Given this list of marker genes Sirt6, Dclk1, Taf8, Cd9, Kdm6a, Slc9a1, Crabp2, Slit1, Stat5b, Agt, Pabir1, Eif4g1, Fgf13, Jade3, Usp9x, Ptch2, Colq, Bcl2, Pi16, Grn, Stk11, Tsg101, Nr3c1, Sesn2, Adam10, Cdh1, Rgs4, Pin1, Prr5, Cgrrf1, Mdk, Ctr9, Dyrk1a, Smarca4 (SWI/SNF related, matrix associated, actin dependent regulator of chromatin, subfamily a, member 4), Disc1, Foxc1, Gsk3b, Chrnd, Rpl4, Twf2, Bcl6, Ednra, Ceacam1, Nanos1, Ttn, Tbx1, Lhx1, Adm, Dmbt1, Haglr, Col9a1, Cd2ap, Gata6, Cib1, Slc23a2, Dab2, Dact3, Raph1, Gpr149, Adnp, Suv39h1, Sfn, Armc12, Osgin1, Adra1b, Slc39a12, Map2k4, Grhl2, Ncor1, Cpne6, Rftn1, Evc, Esr1, Prkg1, Il6ra, Rgma, Ppard, Jade1, Clstn3 (calsyntenin 3), Fbp1, Ccn4, Plau, Hlx, Rab21, Gdf9, Pml, Cyfip1, Musk, Minar1, Pou3f2, Ghrh, Caprin2, Map7, Comt, Edn2, Gins1, Megf8, Smad7, Ahi1, Taf10, Pls1, Ybx3, Rtn4, Adrb1, Nrp1, Bbc3, Slc1a2, Cdk5, Trpv2, Map2, Wnt3a, Rxra, P2rx5, Sertad1, Apod, Mcemp1, Areg, Sav1, Nedd4l, Commd5, Pde4d, Tnr, Mir467a-10, Tgfbr3, Ngf, Fubp1, Scnn1b, Fgf7, Plxna1, Sbds, Wnt11, Sema7a, Rarb, Nr5a2, Hoxa11, Fes, Afg3l2 (AFG3-like AAA ATPase 2), Wrn, Chd7, Ppp1r13l, Atp8a2, Bcl2l11, Tmem196, Mir467a-9, Tshr, Cga, Sod1, Atf5, Fam107a, Ist1, Dysf, Rtn4r, Inhba, Sdcbp, Actn3 (NCBI Gene Id 11474), Prkn, Cryab, Zfp568, Selenon, Slc25a33, Alox8, Auts2, Sema6c, Plekha1, Crhr2, Sgpl1, Golga4, Helt, Foxo3, Smpd3, Pik3ca, Lncpint, Lep, Cxcr4, Dhcr7, Serpine1, Gdf2, Impact, Col14a1 (NCBI Gene Id 70486), Mir1a-2, Bmpr1a, Sema3a, Mymx, Taf9b, Spg11, Cdkn1a, Slitrk6, Plac8 (placenta-specific 8), Hsd3b7, Flrt3, Hspa1b, Clasp2, Fmn1, Igfbp7, Sphk1, Gdf5, Wt1, Atn1, Igfbp3, Hnrnpk, Mkks, Bap1, Nppa, Gli1, Zfp830, Akp3, Odad3, Lats2, Lgr6, Guca2b, Alms1, Adipor1, Lgmn, Tex19.1, Ercc5, Dnph1, Mapk11, Hbegf, Slc4a10, Ccm2l, Nlgn3, Dab2ip, Ndufs3, Smad1, Ncoa3, Csnk2a1, Gins3, Stk3, Kdm2a, Sall1, Tmem182, Ptch1, Hrg, Bcan, Ninj1, Ier3ip1, Sema5b, Capn3, Nkd1, Wdr36, Palb2, Nfkbiz, Mul1, Ccdc85b, Sfrp2, Tbx20, Rbp4, Arid2, Dnm2, Drd2, Mir133a-2, Ip6k2 (inositol hexaphosphate kinase 2), Tle5, Ski, Ndufa13, Ehmt2, Gnas, Smo, Heg1, Pnpt1, Notch2, Rpl29, H2-Q2, Rufy3, Sphk2, Socs6, Dcbld2, Sco1, Zfp640, Psap, Lhx2, Apoa5, Pdgfrb, Cgref1, Fhl1, Rmi1, Dnaaf3, Eif2b2, Pelo, Spag9, Mtor, Zfpm2, Rnf157, H3f3a, Pak1, Foxk1, Myl2, Ppp1r9b, Hey2, C9orf72, Prlr, Cdc42, Creb3, Nat8f3, Spry1, Mir34b, Dio3, Ncam1, Thbs3, Sptbn4, Dnajb2, Ptk2b, Mir467a-8, Cldn18, Ghrl, Lamb2, Wnt2, Mir467a-7, Kcnk2, Cdhr2, Garem2, Trp53, Sema4d, Stat3, Nme6, G6pdx, Mir155, Aspm, Sema5a, Ccm2, Acacb, Nin, Gnasas1, Psmd10, Zfp36l1, Gnat2, Brat1, Tiam1, Fosl2, Fgf2, Abcc1, N6amt1, Pparg, Nell2, D1Pas1 (DNA segment, Chr 1, Pasteur Institute 1), Mst1, St7l, Bmp10, Mir21a, Apba1, Rdh10, Sirt1, Fkbp8, Nubp1, Wfs1, Plxna3, Hamp2, Tspyl2, Eif4g2, Iqgap1, Sp2, Ptger4, Cops2, Otoa, Slit3, Gpr21, Olfm1, Dag1, Frzb, Plaat1, Gli3, Cdkn2c, Ly6e, Pdlim5, Myf6, Galnt3, Sfrp1, Stk4, Duox2, Acvr1c, Avpr1a (arginine vasopressin receptor 1A), Smad3, Gdf15, Ccar2, Mlst8, Pdgfra, Egfr, Hspa1a, Pou1f1, Extl3, Filip1l, Sertad2, Msx1, Ptprj, Gdi1, Reg1, Gnat1, Bst2, Csf1r, Nf2, Kif26b, Ccl11, Fto, Fshr, Wdr11, Ints1, Slc12a2, Mag, Eif4h, Tmprss11d, Por, Myoz1, Ncapg2, Hoxa5, Rptor, Prickle1, Bdkrb1, Stc2, Ntrk3, Enpp1, Flvcr1, Mme, Meaf6, Gigyf2, Pax7, Cobl, Fgf9, Tnfrsf12a, Ercc2 (NCBI Gene Id 13871), Dspp, Kmt2d, Ilk, Prdm4, Ulk1, Ddx39b, Kmt2c, Plxna4, Mt1, Trim32, Itga4, Sec61a1, Kat2a, Parp1, Gas1 (NCBI Gene Id 14451), Dicer1, Cited2, Macf1, Acvrl1, Cpq, Sesn1, Plg, Cd44, Kpna1, Wnt7b, B4galnt2, En1 (engrailed 1), Map1b, Ppara, Large1, Sohlh2, Col3a1, Klf5, Hmga2, Lin7a, Wnt7a, Tchp, Adam15, Rspo2, Tead1, Fgf8, Selenom, Gmnc, Yap1, Sik3, Rims1, Rbm10, Pmp22, Aaas, Efna5, Ankrd11, Mycbp2, Hnf4a, Gjd4, Spag6l, Tnks2, Chaserr, Smad2, Ppp2r3a, Ttl, Ep300, Shtn1, Sox9, Gap43, Cdk1 (NCBI Gene Id 12534), Brd4, Apc, Hesx1, Gsk3a, Atrx, Mir467a-6, Npm1, Cacng7, Slc6a3, Dnajc2, Ang2, Dipk2a, Gm34220, Ndufs6, Plac1, Hdac2, Bmp4, Sbf1, Adcy10, Tal2, Ccn3, Acvr1b, Prkcz, Fn1, Plag1, Hnf1b, Anxa1, Bmpr2 (bone morphogenetic protein receptor type 2), Tmed2, Bcl11a, Cd38, Ssna1, Dip2b, Ing5, Cav3, Eno1b, Tfcp2l1, Foxp1, H3f3b, Pou4f3, Tns2, Alcam, Rasal1, P3h1, Cep43, Mesp1, Mir467a-4, Alkbh1, Ptpn11, Sall4, Gata3 (NCBI Gene Id 14462), Rnf6, Arx, Sema3f, Fbxw10, Sertad3, Prlh, Lin7b (lin-7 homolog B, crumbs cell polarity complex component), Gpat4, Sema4f, Tnc, Mir449a, Ndel1, Shbg, Mymk, Mustn1, Slc6a4, Tsc22d4, Ereg, Tcf7l2, Ptn, Mapt, Fkrp, Lzts2, Agr2, Draxin, Rara (retinoic acid receptor, alpha), Pim1, Zmat3, Ninj2, Mtm1, Tomm70a, Ntn1, Bcl9, Spag6, Jade2, Synb, Phip, Cyba, Phlda2, Cxcl12, Syt4, Adrb2, Cntf, Srf, Six4, Krtap21-1, Sema6d, Fbln5, Med1, Syt1 (synaptotagmin I), Vangl2, Cela1, Lmx1b, Matn1, Rbbp7, Zp3, Gas2, Ei24, Igfbp5 (NCBI Gene Id 98676), Nek1, Mstn, Ift80, H3f5, Hsf1, Cdkn2a (cyclin dependent kinase inhibitor 2A), Sox17, Ascl3, Robo1, Hamp, Igfbp4, Prkar1a, Hdgfl2 (NCBI Gene Id 15193), Nppc, Rxrb, Trim28, Zfyve27, Mapk14, Chrna1, Wfdc1, Dlk1, Sgk1 (serum/glucocorticoid regulated kinase 1), Ddr2, Prmt2, Ercc6 (excision repair cross-complementing rodent repair deficiency, complementation group 6), Syt2, Ezh2, G6pd2, Snhg15, Amh, Pten, Csf2rb, Cryaa, Src, Sgca, Ulk2, Lin7c, Foxc2, Map3k13, Ptk7 (NCBI Gene Id 71461), Ino80, Omg, Hoxd13, C3, Plec, Dlg1, Creb1, Opa3 (optic atrophy 3), Pantr2, Cdkn1b, Stra6, Hmga1, Cth (NCBI Gene Id 99582), Prkdc (protein kinase, DNA activated, catalytic polypeptide), Crk, Unc13a, St8sia2, Trpc5, Epm2a, Thbs1, Naif1, Itgb1, Mecp2, Mir205hg, Atf2 (activating transcription factor 2), Ube3a, Igsf10, Lrp4, Safb, Rnd2, Fgf20, Arih2, Mir133a-1, Smad4, Fxn, Scaper, Agrn, Spry2, Exosc2, H19, Edn1, Cxadr, Nrn1l, Slc12a5, Mael, Sox15, Chek1, Acvr2b, Npy1r, Foxp2, Parp2, Ros1, Mir489, Mmp13, Cdc73, D7Ertd443e, Tbx2, Jarid2, Chst11, Rictor, Dcun1d3, Tgfb2, Ahr, Tro, Llgl2, Avp (NCBI Gene Id 11998), Flt4, Cadm1, Meis1, Brinp3, Gli2, Prox1, Atp1a3, Stc1, Ccr5, Sema3g, Atg16l1, Nfix, 9630013A20Rik, Bnipl (BCL2/adenovirus E1B 19kD interacting protein like), Zpr1, Zfx, Ostn, Atad3a, Ccnb2, Dscam (NCBI Gene Id 78761), Dbn1, Tnn, Gata4, Ceacam2, Eaf2, Ttc8, Pttg1, Socs2, Mir467a-2, Pin1rt1, Kdr, Anapc2, Tenm4, Ppm1f, Sos1, Ddx49, Adra1a, Sox10, Vps13a, Mbd5, Ptgfrn, Spart, Zeb2, Ccnb1, Med12, Arhgap32 (NCBI Gene Id 70677), Gins4, Islr2, Mef2c, Yy1, Afdn, Trp73, Sox2, Cpne9, Ing4, Lmx1a, Ifrd1, Tkt, Xpa, Syt17, Ext1, Brca2, Wnt3, Exosc4, Kif14, Setdb1, Il7, Ghr, Supv3l1, Sash3, Uts2r, Serpine2 (serine (or cysteine) peptidase inhibitor, clade E, member 2, NCBI Gene Id 20720), Fzd7, Nppb, Zmpste24, Fgfr3, Pygo2, G6pc1, Mt2, Htra2, Emx1, Epha7, Cacna2d2, Col27a1, Pkdcc, Hyal1, Kdm1a (lysine (K)-specific demethylase 1A), Abl2, Vil1, Ptprs, Ppt1, Llph, Mfsd8, Myh10 (NCBI Gene Id 77579), Six1, Cpne1, Cdkn2aip, Uri1, Trim46, Rad51b, Tarbp2, Tgfbr2, Tll2, Fzd9, Mex3c, Sorbs2, Map2k5, Ttc3, Zfp639, D130043K22Rik, Unc79, Rag2, Ptk2, Plaa, Trim40, Gamt, Rbbp6 (NCBI Gene Id 97359), Xbp1, Derl2, Wasf1 (WASP family, member 1), Mtpn, Cst5, App, Tnk1, Cd81, Icmt, Eno1 (NCBI Gene Id 269605), Stat5a, Apba2, Mapk1, Brca1, Ccnd2, Cyp19a1, Siah1a, Azgp1, Bmpr1b, Limk1, S1pr1, Smurf1, Flrt1, Ercc1, Nkx6-1, Ctc1, Dusp10, Nbn, Slitrk1, Hoxd11, Slc9a6, Gh, Mt3, Phb1, Vps13b, Clic4, S100b, Adrb3 (NCBI Gene Id 11556), Nog, Pkm, Myh6, Actr3, Cacna1c, Wwc2, Ddr1, Prdm11, Cfl1, Mmp14, Eppk1, Igfbp1, Tgfb1, Ptk6, Lamtor2, Gpx4, Garem1, Usp47, Cyfip2, Nrp2, Mapkap1, Slc25a25, Pex5, Hdac3, Gng4, Notch1, Ctdp1 (CTD phosphatase subunit 1), Add1, Wnt5a, Drd3, Dll1, Shh, Trip10, Lamtor1 (NCBI Gene Id 66508), Hopx, Mir449b, Rln1, Epb41l5, Slc44a4, Atrn, Pou4f2, 2810429I04Rik, Dusp6 (NCBI Gene Id 67603), Psapl1, Mcub, Rhoa, Lrp1, Smarca2, Rc3h2, Bbs4, Hyal2, Tnfaip6, Tmtc3, Igf1, Tmprss4, Ankrd26, Cdkl3, Bltp1, Rerg, Npr2, Col6a1, Lrp6, Poc1a, Ncbp1, Wnt10b, Dmd (NCBI Gene Id 93863), Cirbp, Gpd2, Rarg, Il9, Apoe, Il9r, Plcb1, Kat7, Vcl, Cer1, Armc10, Fgf1, Dvl1, Rims2 (NCBI Gene Id 72660), Septin7, Spg21, Tmem108, Slco1a6, Carm1, Cpne5, Dcaf1, Ptx3, Lpar3, Xirp1, Vps54, Selenop, Camk2d, Ghrhr, Pum2, Mad2l2, Gpc3, Ihh, Dcun1d5, Pafah1b1, Dmbx1, Bbs2, Kcnj8, Brinp2, Cxcl16, Cttn, Fgfr1, Tbx5, Six3, Ikzf1, Igfbpl1, Rtf1, Zmiz1, Dcx, Meg3, Edn3, Bin3, Akt1, Tmem38b, Nkx2-5, Mir124a-2, Psrc1, Il3, Mir449c, Hdac6, Grem1, Flt3, Mir675, Eif2ak4, Hif1a, Fgfr2, Osgin2, Krt17, Hhex, Sgip1, Prkcb, Insr, Rbpj, Sh3pxd2b, Tfap2c, Pot1b, Stil, Daxx, Foxs1 (forkhead box S1), Esrrb, Ubtfl1, Wwc1, Dbnl, Ecm1, Spr, Dcaf13, Igf2, Rai1, Ar, Msx2, Acsl4, Kazald1, Cox10, Igf1r, Adarb1, Lepr, Mndal (NCBI Gene Id 192690), Cntnap2, Slc25a4, Ppib, Adprhl1, Erbb2, Tbl1xr1, Pcdh15, Zfp950, Nrk, Nipbl, Ppan, Fendrr, Serp1, Zfp418, Spaar, Sptbn2, Sin3a, Fgf10, Mir208a, Csf1, Akap6, Rasal2, Ctnnb1, Arid5b, Cdh4, Mir467a-3, Tgfbr1, Lats1, Sh3glb1, Abl1, Sh3bp4 (SH3-domain binding protein 4), Fstl4, Rps6kb1, Mfsd2a, Wdr48, Nrn1, Cdkn1c, Rack1, Gpam, Tyms, Myo5b, Klf2, Pou5f1, Erbb4, Bcl2l1, Ddx3x, Cflar, Klhl22, Comp, Bloc1s6, Myocd, Rb1, Zc3h12d, Mir124a-1, Mir467a-1, Xrcc2, Picalm, Vegfa, Postn, Hoxb13, Ezr, Lgi1, Adam17, Akirin1, Kdm2b, Wdtc1, Mgll, Crkl, Myod1, Etnk2, Wwtr1, Celf1, Ucn, Clstn1, Cda, Ccn5, Rgs2, Ahsg, Arhgap4, Ryk, Tbce, Bdnf, Ptpn12, Mir34c, Aurka, Itsn2, Pthlh, Nrg1, F2, Gja1, Barhl2, Kdf1, Ghsr, Fdps, Sh3gl2, Dcstamp, Bnc2, Cyp27b1, Pcnt, Stk40, Agtr2, Adipor2, Cdkl5, Slit2, Pak6, Men1, Kif26a, L1cam, Rrad, Sfrp5, Gpx1, Vgll4, Crlf3, Atm, Mir682, Nanog, Syt3, Hpn, Gje1, Akap13, Kdm5b, Exosc9, Nlgn4l, Coa5, Mir467a-5, Norad, Atxn2, Cdkn2d, Ndn, Pdzd11, here is a description of the gene set: Mouse Gene Set: GOBP_GROWTH studied in species Mus musculus The increase in size or mass of an entire organism, a part of an organism or a cell.